The following is a description of a gene set: studied in species Homo sapiens Human Gene Set: MIR6882_3P Genes predicted to be targets of miRBase v22 microRNA hsa-miR-6882-3p in miRDB v6.0 with MirTarget v4 prediction scores > 80 (high confidence targets). from publication Chen Y, Wang X (PMID 31504780), and this is the list of marker genes: SEC22C, CACNA1E, CBL, PPM1L, PRKCA, PHF8, CUL1, DTNA, CREBRF, TMED1, MTF1, TACR3, OTUD4, ZNF544, CSNK1D, PLCXD3, AFF1, MECP2, SLC2A6, SYT9, DCAF1, TNRC6B, SPATA13, PID1, TMEM170B, TGFBR2, RFXANK, PURB, NAV3, ACVR1C, RAPGEF1, TCF7L2, FOXP1, CHGA, CNKSR2, CAV3, ZFAND3 (zinc finger AN1-type containing 3), RAB32, COLGALT1, ANKRD13A, DDIT4, MAP2K4, DAB1, OAS2 (2'-5'-oligoadenylate synthetase 2), TRPS1, GIGYF2, SYT14, ZC3H12B, TMX4, USP42, PRDM16, NCAM1, MYCBP, ADCY2, CDK13, PTPN2, TIMM23B, ALPK3, RUFY2, C6orf89, MAGI1, GLRB, LIN7C, HOXA4, ARIH1, RUNX2, KREMEN1, AQP2, SEPHS1, POGK, OSM, WNT10A, FUT9, RRN3, SNRK, HEG1, TFRC, PTPN13, RTN4RL1, TYRO3, SYN2, VEZF1, LIMK2, SYNPR (synaptoporin), MAP1B, SLC9A5, ZZEF1, STK32A, KPLCE, PRSS12, SLC16A14, WNT5A, CENPV, DISC1, CUEDC1, ASB6, WWC2, CARMIL1, GRPEL1, NCS1, DPY19L4, FBN2, JADE1, ELOVL6, AKT3, RNF216, FRYL, AKIRIN2, AFF4, GATM, ZNF699, DCAF7, RGS2